The following is a description of a gene set: Genes down-regulated in lymphoid primed multipotent progenitors: wildtype versus LYL1 knockout. Human Gene Set: GSE38681_WT_VS_LYL1_KO_LYMPHOID_PRIMED_MULTIPOTENT_PROGENITOR_DN from publication Zohren F, Souroullas GP, Luo M, Gerdemann U, Imperato MR, Wilson NK, Göttgens B, Lukov GL, Goodell MA (PMID 22772404) species: Homo sapiens We compared gene expression differences in Lyl-1 knockout vs wildtype LMPPs KO allele described in Pub Med ID: 21387538, and this is the list of marker genes: DNAJC13, IFI27L2, FNBP4, STK19, ARF6, TNFSF10, SLFN13, PARP14, TDRD7, MORC3, TXNRD1, GBP2, IPO7, NUDT4, BATF, IFIT3, VMP1, WDHD1, ATAD1, IFNG, PELI1, CMTR1, GCH1, AIDA, IRF9, LGALS8, NFE2L2 (NCBI Gene Id 4780), MCL1, ANKFY1, GEM, LMO4, TRIM25, ARL6IP1, SRSF7, SLC25A22, TOR1AIP2, ARID5A, SFT2D2, GPR65, OAS2, GPR83, OAS1, TMEM184B, GZMB, IL2RA, PHIP, CD274, DHX58, FAM111A, CISH, CLIC4, ST3GAL6 (ST3 beta-galactoside alpha-2,3-sialyltransferase 6), GBP7, OGFR, TRIM26, SLC25A28, CHMP5, RSAD2, LGALS3BP, NABP1, CHRNB1, GBP6, ZNF281, ISG20, EEIG1, IRF7, ETNK1, ZFYVE26, SYNE2, KRT31, RNF19B, RBL1, KAT6A, MOV10, STAU1, NOC4L, SCARB2, ZNF654 (zinc finger protein 654), C19orf12 (NCBI Gene Id 83636), IFIT2, EZH2, CNP, RGS1, TRIM34, KPNA1, GBP4 (NCBI Gene Id 115361), LIMA1, IRGM, PDZK1, GZMA, IRF2, APOBEC3B, TLR3, SGK3, MX1, SOCS3, KCNQ1, SH3BGRL2, GADD45G, NFKBIZ, JPH2, PLEKHO1, TRMT10A, MX2, ELOVL6 (ELOVL fatty acid elongase 6), ISG15, GRINA, TASOR2, LYSMD2, CD82, BLTP2, IRF4, FASLG, DAXX, MYD88, TRIM21 (NCBI Gene Id 6737), RBM43, IFIT1B, ZBP1, USP25, LGALS9B, PSMB9, SLFN12L, GPR146, TOR1AIP1, HLA-G, CMTM6, ARF4, TMEM140, VPS54, TOR3A, NBN, RIPK1, MAG, SOCS1, ZNFX1, PDCD10, INSL6, SLC16A1, PUS10, PML, USP18, CASP8, CCRL2, PNPLA2, RTP4, TBRG1 (transforming growth factor beta regulator 1), PARP12, UIMC1, PTPRE, BIRC3, ZUP1, RNF114, IL18R1 (interleukin 18 receptor 1), IFI35, PIGA, PNPT1, MAP3K8, GPR155, DDX24, PPA1, CMPK2, HELZ2, OASL, MITD1, ACSL4, TAP1, STAT3, PARP9, TAPBP, CUEDC1, HLA-E, ILRUN, AGFG1, RNF19A, IRF1, GHITM, NUP153, IL10RA, NAMPT, HSPA5, STAT2, IFIH1, METRNL, ASB13 (ankyrin repeat and SOCS box containing 13), RFC3, ROS1, FAS, TRAFD1, GNRHR, SAMHD1, WIPF1, ADAM22, CXCL10, PIK3C2A, ARG1, STAT1, CAMK2D, PIM2, CCR5